The following is a description of a gene set: p75NTR recruits signalling complexes Mouse Gene Set: REACTOME_P75NTR_RECRUITS_SIGNALLING_COMPLEXES studied in species Mus musculus, and this is the list of marker genes: Ubb, Uba52rt, Myd88, Prkci, Sqstm1, Ripk2, Ubc, Uba52, Traf6, Rps27a, Irak1, Ngfr, Ngf, Ikbkb